Given this list of marker genes Txndc15, Cplx2, 5330429C05Rik, Nop16, Tifab, 4833439L19Rik, Gm26555, Prr7, Pfn3 (NCBI Gene Id 75477), Mir6944, Gm47072, Gm24716, Tmed9, Gm33424, Gm47918, Gm34022, Drd1, Klhl3, Fam193b, Qng1, Hk3, Dbn1, Dok3 (NCBI Gene Id 27261), Gm22777 (NCBI Gene Id 115485905), Uimc1, B4galt7, Mir874, Gm2762, Kif27, Arl10, C630044B11Rik, 4930415C11Rik, Gm5449, Mir7-1, Gm34354, Hrh2 (NCBI Gene Id 15466), Gm6344, Unc5a, Ntrk2, Catsper3, Thoc3, Gm46416, Simc1, Hnrnpk, Rpl13-ps2, Slc28a3, Gm40968, Pdlim7, Gm34245, Gm18473, Cxcl14, 4930555G21Rik, Cdhr2, Grk6, Gm34557, 4930455J16Rik, Ubqln1, Tgfbi, F12, Higd2a, Lman2, Gm46415, Gm34307, Gm34278 (NCBI Gene Id 102637481), Mir6943, 4930526F13Rik, Pcbd2, Ddx41, Sptlc1, Prelid1, Zfp346, Eif4e1b, Smim32, Mxd3, Mir6369, Idnk (idnK gluconokinase homolog (E. coli)), Cltb, Smad5, Rab24, Nfil3, Gm2830, Msx2, Gm24195, Rnf44, Spock1, Sfxn1, Gm16578, 2010203P06Rik, Gm17878, 9530014B07Rik, Macroh2a1, Rgs14, Faf2, Gprin1, 4930451E10Rik, Tspan17, Gm3131, E130119H09Rik, Gm29431, Gm25148, Sncb, Ddx46, Auh, Lect2, Gkap1, 1700066J03Rik, Il9, B230219D22Rik, Slc34a1, Gm3045, Trpc7, Gm16249, Rmi1, Slc25a48, Gm34558, Pitx1, Gm48176, Hnrnpa0, Ror2, Caml, Neurog1 (neurogenin 1), Fgfr4, Neudnr, Nsd1, Mir6945, Fbxl21, Gm10782, Gm18974, Gm48432, here is a description of the gene set: Mouse Gene Set: chr13B1 studied in species Mus musculus